The following is a description of a gene set: After transcription, some RNA molecules are altered to contain bases not encoded in the genome. Most often this involves the editing or modification of one base to another, but in some organisms can involve the insertion or deletion of a base. Such editing events alter the coding properties of mRNA.<BR>RNA editing can be generally defined as the co- or post transcriptional modification of the primary sequence of RNA from that encoded in the genome through nucleotide deletion, insertion, or base modification mechanisms.<BR>There are two pathways of RNA editing: the substitution/conversion pathway and the insertion/deletion pathway. The insertion/deletion editing occurs in protozoans like Trypanosoma, Leishmania; in slime molds like Physarum spp., and in some viral categories like paramyxoviruses, Ebola virus etc. To date, the substitution/conversion pathway has been observed in human along with other mammals, Drosophila, and some plants. The RNA editing processes are known to create diversity in proteins involved in various pathways like lipid transport, metabolism etc. and may act as potential targets for therapeutic intervention.<BR>The reaction mechanisms of cytidine and adenosine deaminases is represented below. In both these reactions, NH3 is presumed to be released:<BR> studied in species Homo sapiens part of: Metabolism of RNA Reactome Pathway: mRNA Editing, and this is the list of marker genes: APOBEC3C, A1CF, APOBEC3H, APOBEC2, APOBEC4, ADARB1, ADAR, APOBEC3A, APOBEC3B, APOBEC1